Given this list of marker genes PRDX2, KLF4, PLK5, SPI1, PRF1, RELA, DAPK1, ABI3, DLEC1, RBMS3 (NCBI Gene Id 27303), TNFRSF10B, LAPTM5, here is a description of the gene set: Reactions triggered in response to the presence of a tumor cell that act to protect the cell or organism. species: Homo sapiens Human Gene Set: GOBP_DEFENSE_RESPONSE_TO_TUMOR_CELL